Given this list of marker genes USP48, PLAA, USP8, NR3C1, SCN11A, GATA6, MKKS, AP1S3, CITED2, FLT4, OCA2, TBX20, RBM8A, SNRPN, NDN, LRP5, PRKAR1A, PIEZO1, MYH7, ALB, MAGEL2, FN1, RNF13, JAK2 (Janus kinase 2), NFKBIA, SCN10A, TRAF7, EPHB4, CDH23, F5, SCN9A, ATRX, NSD1, NKX2-5, VEGFC, MYD88, IL36RN, MYH6, TLL1, SEC63, TIE1, CALR, ATP7B, IRF4, ZNHIT3, ACTC1, APC2, BRAF, GATA4, TP53, EIF2AK4, TGM1, IKBKG, FIBP, MEFV, GJC2, PRKCSH (PRKCSH beta subunit of glucosidase II), ANGPT2, here is a description of the gene set: species: Homo sapiens Pedal edema An abnormal accumulation of excess fluid in the lower extremity resulting in swelling of the feet and extending upward to the lower leg. Human Gene Set: HP_PEDAL_EDEMA